Given this list of marker genes DGKE, ZFC3H1, SULF2, PDCD6, FGFR1, OR4D2, NDUFA3 (NADH:ubiquinone oxidoreductase subunit A3), PUS1, KCNQ3, VPS13B, ATRN, UQCC1, ZCCHC24, ENTREP3, ANK1, AHRR, ZCCHC14, GSDMB, AKAP9, DYRK2, IKBKB, HCN3, RGS22, RSKR, NUFIP2, CSMD3, SPO11, MYO7A (NCBI Gene Id 4647), SAMD9, GOLGA7 (golgin A7), ZFP64, DNAH17, PCNT, ARFRP1, FAM217B, CHCT1, TBK1, CSNK1D, JMJD8, SLCO2B1 (NCBI Gene Id 11309), MSLNL, PPM1E, GGA3, FANCA, THBS3, CACNA1H, PIGS, FABP4, DCAF13, GRIN2C, CHD7, PKHD1L1, SEPTIN4, ARFGEF2, EP400, HOXA4, ZFHX4, ZNF529, LPO (lactoperoxidase), SLC6A3, HOOK3, TRIM25, NCOA6, SPCS2, SIGLEC1, POP1, UTS2R, PANX2, RCE1, CLPTM1L, TAC4, CACNA1G, ZNF707, ZMIZ1, NID2, ZNF569, ARRB1, NSMCE2, HEPACAM2, AGAP2, BLTP2, GDF6, ZNF461, MYH7B, TG, RIMS2, MYO9B, ADGRB1, UBE2I, SYTL2, RADIL, HOXA3, TESMIN, ARC, here is a description of the gene set: Human Gene Set: NIKOLSKY_MUTATED_AND_AMPLIFIED_IN_BREAST_CANCER Genes both mutated and amplified in a panel of 191 breast tumor samples. species: Homo sapiens from publication Nikolsky Y, Sviridov E, Yao J, Dosymbekov D, Ustyansky V, Kaznacheev V, Dezso Z, Mulvey L, Macconaill LE, Winckler W, Serebryiskaya T, Nikolskaya T, Polyak K (PMID 19010930) A single cancer cell contains large numbers of genetic alterations that in combination create the malignant phenotype. However, whether amplified and mutated genes form functional and physical interaction networks that could explain the selection for cells with combined alterations is unknown. To investigate this issue, we characterized copy number alterations in 191 breast tumors using dense single nucleotide polymorphism arrays and identified genes with copy number gain organized into 30 amplicons. Amplicons were distributed unequally throughout the genome. Each amplicon had distinct enrichment pattern in pathways, networks, and molecular functions, but genes within individual amplicons did not form coherent functional units. Genes in amplicons included all major tumorigenic pathways and were highly enriched in breast cancer-causative genes. In contrast, genes with somatic mutations in breast cancer were distributed randomly over the genome, did not represent a functionally cohesive gene set, and were relatively less enriched in breast cancer marker genes. Mutated and gained genes did not show statistically significant overlap but were highly synergistic in populating key tumorigenic pathways including transforming growth factor beta, WNT, fibroblast growth factor, and PIP3 signaling. In general, mutated genes were more frequently upstream of gained genes in transcription regulation signaling than vice versa, suggesting that mutated genes are mainly regulators, whereas gained genes are mostly regulated. ESR1 was the major transcription factor regulating amplified but not mutated genes. Our results support the hypothesis that multiple genetic events, including copy number gains and somatic mutations, are necessary for establishing the malignant cell phenotype.